The following is a description of a gene set: Human Gene Set: GSE7509_UNSTIM_VS_TNFA_IL1B_IL6_PGE_STIM_DC_DN from publication Dhodapkar KM, Banerjee D, Connolly J, Kukreja A, Matayeva E, Veri MC, Ravetch JV, Steinman RM, Dhodapkar MV (PMID 17502666) The ability of dendritic cells (DCs) to activate immunity is linked to their maturation status. In prior studies we have shown that selective antibody-mediated blockade of inhibitory FcgRIIB receptor on human DCs in the presence of activating immunoglobulin (Ig) ligands leads to DC maturation and enhanced immunity to antibody-coated tumor cells. Here we show that Fcg receptor (FcgR) mediated activation of human monocytes and monocyte-derived DCs is associated with a distinct gene expression pattern, including several inflammation associated chemokines as well as type 1 interferon (IFN) response genes including the activation of signal transducer and activator of transcription 1 (STAT1). studied in species Homo sapiens Genes down-regulated in dendritic cells: untreated versus inflammatory cytokine cocktail., and this is the list of marker genes: TMEM163, MIRLET7G, GPR139, UNC13B, MIR150, SCNN1G, NHLRC1, KIFC2, MACROD2, STX1A, OPN1SW, NOL4, PWWP2A (NCBI Gene Id 114825), LY6G5B, PPY, CNTNAP3, MIR346 (NCBI Gene Id 442911), MIRLET7I, BGLAP (NCBI Gene Id 632), ABHD16A, KCNRG, RBM25, WDR17, TMEM191C, RSAD1, MIRLET7E, IL27, CLDN23 (NCBI Gene Id 137075), C4BPA, KRTAP3-2, ENTREP2, LRRC4B, RMRP, CX3CR1, NRSN1, MIR301B, MIR455, POPDC3 (NCBI Gene Id 64208), AGO2, PAX7, STX4 (syntaxin 4), SLC4A1, AMT, ZC3H6, MIR345, IFNA5, ST8SIA5 (ST8 alpha-N-acetyl-neuraminide alpha-2,8-sialyltransferase 5), MORN3, PBX4, MT3, HOXA4 (homeobox A4), SCARNA17, NRL, SSTR4, SNHG1, RNY3, TMF1, ANKRD22, TRIM11, CREBL2, NUP210L, NLGN3 (NCBI Gene Id 54413), FRS3, AHNAK2, GNRH1, NECAB3, SCUBE1, TNFAIP8L3, MIR598, SALL3, HOXB7, ACR, ST6GALNAC1, CGNL1 (NCBI Gene Id 84952), TRAF3IP1, MIR210, SLC39A5, KCNAB1, MIR30D, MIR615, GAS5, MIR27A, RRBP1, KRTAP4-2, MIR200C, RSF1, ALAS2, MIRLET7B, TSSK4, PHLDB3, RYR3, LMTK3, LIN28B, MARCHF11, GGNBP1, OXT, FLRT1, LRRC3, MIR28, HPN, KCNMB3, LYZL4, KCTD16, KCNAB3, ADAMTS3, SNORD73B, CTRC, MESP2